The following is a description of a gene set: Activin was initially discovered as an activator of follicle stimulating hormone in the pituitary gland. It has since been shown to be an important participant in the differentiation of embryonic cells into mesodermal and endodermal layers. Activin binds the Activin receptor and triggers downstream events: phosphorylation of SMAD2 and SMAD3 followed by activation of gene expression. Activins are dimers comprising activin A (INHBA:INHBA), activin AB (INHBA:INHBB), and activin B (INHBB:INHBB). Activin first binds the type II receptor (ACVR2A, ACVR2B) and this complex then interacts with the type I receptor (ACVR1B, ACVR1C). The type II receptor phosphorylates the type I receptor and then the phosphorylated type I receptor phosphorylates SMAD2 and SMAD3. Dimers of phosphorylated SMAD2/3 bind SMAD4 and the resulting ternary complex enters the nucleus and activates target genes. Reactome Pathway: Signaling by Activin part of: Signaling by TGFB family members studied in species Homo sapiens, and this is the list of marker genes: INHBA, FST (NCBI Gene Id 10468), ACVR2B, MAPK1, ACVR1C, FOXH1, ACVR1B, SMAD4 (SMAD family member 4), MAPK3, SMAD2, DRAP1, FSTL3, ACVR2A, INHBB, TGFBR3, INHA, SMAD3